The following is a description of a gene set: Enlarged epiphyses Increased size of epiphyses. species: Homo sapiens Human Gene Set: HP_ENLARGED_EPIPHYSES, and this is the list of marker genes: COL2A1, CCN6, COL10A1, CLCN5, TRAPPC2 (NCBI Gene Id 6399), PIK3R1, COL11A2, CYP27B1, CYP2R1, GDF5, COG4, SLC34A3, VDR, CKAP2L, NKX3-2